Given this list of marker genes Rtel1, Ercc1, Ercc4, Xrcc1, Xrcc4, here is a description of the gene set: studied in species Mus musculus Any process that stops, prevents or reduces the frequency, rate or extent of telomere maintenance in response to DNA damage. Mouse Gene Set: GOBP_NEGATIVE_REGULATION_OF_TELOMERE_MAINTENANCE_IN_RESPONSE_TO_DNA_DAMAGE